The following is a description of a gene set: Human Gene Set: MIR1296_5P studied in species Homo sapiens Genes predicted to be targets of miRBase v22 microRNA hsa-miR-1296-5p in miRDB v6.0 with MirTarget v4 prediction scores > 80 (high confidence targets). from publication Chen Y, Wang X (PMID 31504780), and this is the list of marker genes: TRIL, SLC38A5, TGDS, NRCAM, CLEC12B (NCBI Gene Id 387837), FOXJ2, ELAC1, PPP1R11, SF3B2, LCOR, POLA1, ZNFX1, PDZK1IP1, SETDB1, ZNF521, HECTD4, CGGBP1, DARS1, EGR2, TMEM239, SSUH2, SYN2, SNRPB, SFPQ, SLC41A1, WASHC4, UGT3A1, SYN1, RNF123, SLC1A1, CEBPZOS, CTNND1, ERV3-1